The following is a description of a gene set: Human Gene Set: GOBP_NEGATIVE_REGULATION_OF_DEPHOSPHORYLATION species: Homo sapiens Any process the stops, prevents, or reduces the frequency, rate or extent of removal of phosphate groups from a molecule., and this is the list of marker genes: CHP1, INPP5K, EPM2A, IQGAP1, URI1, DRD2